The following is a description of a gene set: Notch signaling species: Homo sapiens Human Gene Set: WP_NOTCH_SIGNALING_WP61, and this is the list of marker genes: HEY1, MAGEA1, JAG1, PIK3R1, MAML2, EP300, DLL3, MAML3, MTOR, GATA3, RBPJ, HES6, CUL1, HEY2, SAP30 (Sin3A associated protein 30), ITCH, NCSTN, HIF1A, RING1, CIR1, NFKB1, DTX1, PSENEN, FBXW7, NOTCH1, JAK2, NOTCH4, APH1B (aph-1 homolog B, gamma-secretase subunit), MYC, APH1A, FHL1, SKP1, PIK3R2, LCK (LCK proto-oncogene, Src family tyrosine kinase), ADAM17, SPEN, TLE1, MAML1, SNW1, HDAC2, HES5, PSEN1, AKT1, PTCRA, SRC, HDAC1, CCND1, NOTCH2, CDKN1A, NCOR2, HES1, NUMBL, PSEN2, DLL4, NUMB, STAT3, JAG2, NCOR1, GSK3B, DLL1, NOTCH3